The following is a description of a gene set: Neighborhood of RRM2 Neighborhood of RRM2 ribonucleotide reductase M2 polypeptide in the GNF2 expression compendium studied in species Homo sapiens Human Gene Set: GNF2_RRM2, and this is the list of marker genes: CCNB2, AURKA, PLK1, CENPE, TYMS, MCM4, MCM6, CDC20, RRM2, GMNN (NCBI Gene Id 51053), MCM3, ESPL1, MKI67, BUB1, BIRC5, CDCA8, FOXM1, DLGAP5, UBE2C, SMC1A, AURKB, KIF11, CCNA2, ZWINT, ASPM, CDK1, HMMR, NDC80, MELK, LMNB1, TOP2A, CENPF, MCM2, H2AX, RRM1, BUB1B, KIF18B, PCNA, NUSAP1, CENPM